Given this list of marker genes GUCY1A2 (NCBI Gene Id 2977), ARL6IP5, RPRD1A, PCDHA2, KHDRBS2, CDK17, ZNRF3, NMD3, SMAP1, CYRIA (CYFIP related Rac1 interactor A), DNAJB11, WASF3, GPATCH2L, ATP2B2, POLR3G (RNA polymerase III subunit G), SYT4, TMEM135, AASS, FAM83A, USP33, TMPRSS13, SRGAP2, GDA, CAND1, LIN9, SBNO1, ENOX2, PPP6R2, DMRTC1, ZNF331, GDAP2, PCDH9, USP9Y, TNFSF10, NCAM2, JOSD1, NXPE3, CERS3, TBC1D1, MAP3K19, KHDRBS1, KLF12, CCND2, THBS2, PCDH11Y, CLDN12, KDM7A, MID2, DACH1, NFAT5, UBE2W, EGR4, SERPINE2, SOX6, TMEM225, MYEF2, PITPNC1, MEAF6, SYNPO2 (NCBI Gene Id 171024), SMARCAD1, SNTB1, U2SURP, HIVEP1, BICC1, COL22A1, ZNF678, PHACTR2, TPGS2, PBX2, SSR1, PMP2 (NCBI Gene Id 5375), JADE3, TENT4B, IFT56 (NCBI Gene Id 79989), AFG2A, ZDHHC17 (zinc finger DHHC-type palmitoyltransferase 17), SLC4A4, NIPAL4, SUPT16H, TRPC5OS, CEP41, LRRC25, PLXNA2, ELL, TSHZ3, PRTG, KCNMB2, CARNMT1, FAM168A, SEMA6A, SHROOM4, MAGEA10, TSC22D2, XPO6, ZNF236, TLE4, HBEGF, PCDH20, RAB10, ADSS2, FXN, IRAG1, DMRTC1B, HMMR, BMF, AR, SYDE2, PPP1R9A, SAMD4A, PCDH7, PCDH11X, SPECC1, DCC, ARHGEF6, PAPPA, SYCP1, MYBL1, CDK6, CD1E, PSD3, FBXO43, TMEM179B, NEDD9, CPNE3, CCK, CDC42, MLLT10, TMEM267, GABRA4 (gamma-aminobutyric acid type A receptor subunit alpha4), HMGN2, TCEA1, DCX, WDR26, WNK3, SSB, RREB1, WTAP, SLC6A11, RABL6, MSL2, AAK1 (AP2 associated kinase 1), DSG3, ITGAV (NCBI Gene Id 7449), PLOD2, STK39, HNRNPA2B1, VPS41, UTY, PSAPL1, SENP1, PELO, ATF7IP, PARD6G, RWDD2B, SESN3, ACBD3, TMEM30A, IRF2, MAP7D2, DYRK1A, ZHX3, B4GAT1, ZFPM2, VAMP3, UBE2E2, ATXN1, LPCAT4, DGKB, LIN7C, HIPK3, NCKAP5L, TULP4, SLMAP, CCDC34, TBP, NAV2, NCOA2, PARP11, ARL6IP6, SEPSECS, AFF2, AFF4, CYLD, IRF2BPL, TLK1, MPPED2, SKIL, GOLPH3, B4GALT1, LGALSL, SETD5, SAR1A, TGFBR3, DIS3, RCAN2, STX11, RBMS3, GNG4, TRIM6, DLG1, GIT2, PRKAA1, PDE3B, MLF1, CCDC89, EVI5, HTR1B, EPB41L2, EDEM3, TET2, SLC11A2, GOLGA6L6, SOX9, TCF4, TAFA4, NRG1, FAXC, GDPD1 (NCBI Gene Id 359824), IL6, CAAP1, SYT1, HCFC1, ADIPOQ, DPYSL2, RNF111, ABCB7, TIPARP, SLC39A8, ZC2HC1A (NCBI Gene Id 51101), CNOT6, EIF4B, LZTFL1, KIF20A, RAD54B, CTDSPL, PEX3, ZC3H6, PRKAR2A, ARFGEF2, ARSB, TLCD5, SH2B1, RNF11, TMX4, STAT3, ARSJ (NCBI Gene Id 79642), NBEA, AMOTL1 (NCBI Gene Id 154810), MRPL2, CD47, CNTROB, FSBP, USP32, RFK, CDH4, HS3ST4, DEPDC1B, MOB3C, ZKSCAN1, EIF1B, ALDH6A1, QKI, AK2, EI24, CACNA2D1 (calcium voltage-gated channel auxiliary subunit alpha2delta 1), TMCO1, GABRA1, CPA4, RBBP4, SLC44A5, TMEM33, CUL4B, POGLUT1, GNPTAB, RUNX2, RGS7, FBXO38, CACNB4, ACYP2, ARRDC3, SLC5A3, DYNLT3, GLS, SRSF8, PACRGL, OXGR1, NHS, SMARCA1, DGKG, ERBB4, UBE3A, CPEB3, A1CF, PPP4R4, UGCG, ASB7, SH3TC2, GAP43 (growth associated protein 43), PPIG, ZNF783, CNTN4, TET1, PHF8, PCGF5, ROBO1, NDUFA5, GRIA3, ATG14, HERC5, CMIP, RCOR1, MTMR10, SPRING1, PIK3R1, NAA16, SHTN1, CSRNP3, GRPEL2, CD9, TRMT5, TMTC2, NEK7, FSTL5, PER3 (NCBI Gene Id 8863), WEE1, CEP85L, RIOK2, PI4K2B, EPPK1, HTATIP2, IL1A, PAK3, RHOBTB1, SLC12A6, TBL1XR1, FBXO15, RPRD2, APPBP2, ZBTB1, POLR1D, FER, GHR, DCAF12L1, ATP11B, MICU3, TMEM38B, RGS13, SYT6, RBM17, CAMKK2, CHSY3 (chondroitin sulfate synthase 3), TDRD1, XIAP, ETV1, CA8, RORA, ARHGAP28, SOX4, ST6GAL2, ZNHIT6, PRR14L, MRTFB, PLAUR, PRDM2, PTGIS, UGT8, WNT7B, PCDH10, CENPH, ADAMTS9, RBM46, AMOT, CNTNAP2, COL16A1, SPATA2, PBRM1, WDR44, ALOX15, CPNE4, AZI2 (NCBI Gene Id 64343), HSD3B7, FGF13, TSN, TRAF3, RNF149, PHTF2, ING3, KDM4B, ELOVL5, SNX30, TFRC, LEKR1, PDIK1L, AHDC1, GMDS, CXXC4, TRA2A, MORC1, ASTN1, SP4, CRY1, DSCAM (DS cell adhesion molecule), FAN1 (NCBI Gene Id 22909), TMEM123, here is a description of the gene set: species: Homo sapiens from publication Chen Y, Wang X (PMID 31504780) Human Gene Set: MIR196A_1_3P Genes predicted to be targets of miRBase v22 microRNA hsa-miR-196a-1-3p in miRDB v6.0 with MirTarget v4 prediction scores > 80 (high confidence targets).